Given this list of marker genes Mre11a, Aste1, Polq, Dclre1c, Xrcc4, Xrcc1, Rbbp8, Ptbp1, Exog, Ercc1, Ercc4, Endog, Setmar, Rad50, here is a description of the gene set: studied in species Mus musculus Catalysis of the hydrolysis of ester linkages within a single-stranded deoxyribonucleic acid molecule by creating internal breaks. Mouse Gene Set: GOMF_SINGLE_STRANDED_DNA_ENDODEOXYRIBONUCLEASE_ACTIVITY